Given this list of marker genes KRAS, MSH6, PLAG1, TGFBR2, PIK3CA, PMS2, EPCAM, MLH1, MSH2, PMS1, here is a description of the gene set: Human Gene Set: HP_SALIVARY_GLAND_NEOPLASM species: Homo sapiens A tumor (abnormal growth of tissue) of a salivary gland. Salivary gland neoplasm